The following is a description of a gene set: studied in species Homo sapiens Human Gene Set: chr14q32, and this is the list of marker genes: VRK1, GON7, IGHVII-43-1, CEND1P1, LINC02321, OTUB2, BTBD7 (BTB domain containing 7), IGHVII-65-1, IGHV5-78, IGHD1-14, SNORD114-12, MIR770, IGHVIII-2-1, IGHD4-17, IGHV1-69-2, MIR485 (NCBI Gene Id 574436), SNORD113-8 (NCBI Gene Id 767568), MIR487A, IGHVII-30-1, KIF26A-DT, IGHVII-46-1, DICER1, RAB42P1, SERPINA6 (serpin family A member 6), LINC02279, MIR493, IGHV3-54, MIR412, MIR494, IGHE, SCARNA13 (NCBI Gene Id 677768), SNORD114-23, IGHV3-62, RNU7-30P, MIR377, IGHV1-12, LINC02299, IGHVII-51-2, IGHVII-1-1, IGHV7-40, MIR4710, SNORA11B, IGHJ4, SNORD113-7, IGHD3-9 (immunoglobulin heavy diversity 3-9), RTL1, MIR541, SNORD113-4, IGHV1-58, EFCAB11, IGHV3-29, RNU2-33P, IGHV4-28, IGHV3-52 (NCBI Gene Id 28421), IGHV1-14, IGHV2-26, RN7SL634P, IGHV3-37, MIR203A, LINC02280, IGHD3-22, FAM181A, ATG2B, IGHA2, IFI27L1, SYNE3-AS1, CCDC88C, IGHD5-24, MIR543, LINC02285, KCNK13, TRMT61A-DT, MARK3, ENSG00000285205 (novel transcript), MIR382, RPS6KA5, CDCA4, IGHV3-57, MIR433, FBLN5, LINC00239, IGHVII-49-1, MIR203B, IGHD1-1, MIR411, RN7SL523P, DDX24 (DEAD-box helicase 24), LINC02287, EXOC3L4 (exocyst complex component 3 like 4), PPP4R4, SERPINA3, HSP90AA1, ENSG00000200150, RPL10AP1, IGHV1-3, SNORD114-14, AKT1, IGHV2-70, RN7SKP255, MIR409, MEG8, AMN, RN7SL472P, IGHVII-22-1, MTA1-DT, MIR431, LINC02312, MIR544A, GSC, IGHD3-10, MIR376A2, MIR539, MIR4539, TRAF3 (TNF receptor associated factor 3), MEG3, MIR323B, LINC01550 (NCBI Gene Id 388011), TECPR2, SNORD114-24, LINC02320, LINC00605, PAPOLA-DT, MIR493HG, MIR1197, IGHD2-2, ADIPOR1P2, MIR665, PPP1R13B, TUNAR, IGHV3-35, CINP, ZFYVE21, HOMER2P1, CCDC197, BEGAIN, PPP1R13B-DT, IGHV5-10-1, RIN3, IGHD6-19, LINC00226, BRF1, INF2, MIR4507, BDKRB1 (bradykinin receptor B1), IGHG2, RPL23AP10, COPDA1, MIR8071-2 (microRNA 8071-2), LINC02292, IGHVII-74-1, AK7, IGHM, NDUFB4P11, IGHD6-25, IGHV3-64D, IGHVII-40-1, MIR1193, SNORD114-26, DEGS2, PLD4, IGHJ3, ITPK1-AS1, PEBP1P1, RPL21P12, SNORD114-4, IGHVII-30-21, RPL17P4, IGHVIII-44 (NCBI Gene Id 28345), IGHD2-21, YY1, CLBA1, MIR329-2, TTC7B, ENSG00000230805, DIO3OS, WDR25, MIR654, IGHVII-28-1, DICER1-AS1, ENSG00000258460, IGHVII-60-1, VESTAR, SNORD114-2, IGHV3-33-2, DYNC1H1, IGHV3-65, ATXN3, IGHV4-31, IGHV3-50, RNU4-68P, MIR655, IGHJ3P, IGHV1-46, IGHVIII-76-1, CYB5AP3, ENSG00000201500, CRIP2, C14orf132, SLC25A47, IGHD2-8, MIR4538, RPS20P33, MIR496, IGHV1-69 (NCBI Gene Id 652126), UNC79, SNORD114-29, RPL23AP11, RPL15P2 (ribosomal protein L15 pseudogene 2), MOAP1, LINC02298, IGHV3-79, IGHV3-53, MIR345, BDKRB2 (NCBI Gene Id 624), SNORD114-9 (small nucleolar RNA, C/D box 114-9), IGHVIV-44-1, BAG5, FOXN3, IGHVIII-67-4, ATP6V1G1P1, ITPK1, MIR380 (NCBI Gene Id 494329), TRIP11, IGHVII-62-1, IGHV3-6, IGHVIII-38-1, CKS1BP1 (NCBI Gene Id 317780), SNORD114-19, SLC24A4, RNU6-1258P, RNU6-790P, LINC02914, IGHD6-6, MIR127 (microRNA 127), GSKIP, IGHJ5, LINC02304, PPP2R5C, RPL21P11, LINC02323, TDRD9, IGHD2-15, IGHV7-81, TEDC1, IGHD1-26, PPP4R3A, IGHV3-69-1, SNORD113-2, IGHV3-30-2, IGHV3-38 (NCBI Gene Id 28429), GCSHP2, IGHVIII-47-1, ASB2, RNU6-684P, MIR342, NUDT14, RN7SKP108, RNU6-366P, MIR136, MIR410, SNHG10, IGHV7-4-1, IGHV4-61, IGHV3-23, IGHV7-56, ENSG00000303620, LINC02295, IGHVIII-5-1, TMEM179, CCDC85C, IGHV3-15, MIR1185-1, IGHV1-69D, IGHV2-70D, ENSG00000297609, CPSF2, UBR7, SNORD114-20, CALM1, GOLGA5, SLC20A1P1, SNORD114-10, CLMN (calmin), CCNK, SNORD114-3, FAM181A-AS1, YY1-DT, IGHV3-75, MIR6764, RPS2P4, DIO3, CATSPERB, IGHV3-41, RPL36AP4, MIR758 (NCBI Gene Id 768212), RPSAP5, SERPINA9, SNORD114-1, RNU6-244P, RCOR1, SETD3, SNORD114-6, HMGB3P26, ENSG00000258702, MIR6765, DLK1 (NCBI Gene Id 8788), LINC02325, SNORD113-3, COA8, MIR329-1, SNORD114-28, SNORD114-5, IGHD6-13, IGHV3-73, IGHV3-22, SNORD114-21, IGHD3-3, JAG2, ELK2BP, IGHV1-17, RNU7-160P, ADAM6, IGHG4, WARS1, TNFAIP2, LINC02317, SNORD114-11, MIR487B, IGHV8-51-1 (immunoglobulin heavy variable IGHV8-51-1 (non-functional)), IGHA1, LINC02314, IGHVIII-25-1, LINC00221 (long intergenic non-protein coding RNA 221), IGHV4-39, ENSG00000222095, MIR381, SNORD113-5, IGHV3-43, IGHJ1P, NRDE2, SERPINA2, LINC00677, PRIMA1, IGHV1-68, SERPINA5, IGHV3-60, GPR132, IGHD5-12, RNA5SP389, ENSG00000295850, IGHV1-45, ENSG00000202275, MIR5195, LINC00524, ENSG00000287501, IGHV3-7, MTA1, MIR656, BCL11B, LINC02691, IGHV7-27, LINC02318, ATP5MC1P1 (ATP synthase membrane subunit c locus 1 pseudogene 1), RNU6-91P, IGHV5-51, C14orf180, XRCC3, IGHV3-64, MIR376A1, LINC02291, IGHV3-72, MIR369, RPL21P13, LINC00523, CHGA, MIR495, SIVA1, IGHV4-55, HHIPL1, RN7SL714P, COX8C, IGHV7-34-1, NDUFB1, CHORDC2P, IGHV1-67, IGHJ1 (immunoglobulin heavy joining 1), MIR8071-1, IGHV3-20 (immunoglobulin heavy variable 3-20), IGHV3-30, CYP46A1, FAM30A, SNORD113-6, SERPINA4, IGHD4-11, KLC1-AS1, GPR68, LINC02960, MIR2392, MIR134, RN7SKP92, PAPOLA, IGHVIII-13-1, SNORD113-1, RPL3P4, MIR370, MIR300, POLR3GP1, FOXN3-AS1, ZBTB42, IGHD3-16, IGHVII-67-1, SNORD114-7, IGHD7-27, IGHV6-1, IGHV2-5, IGHVIII-82, IGHV1-2, IGHJ2, MIR432, DGLUCY, IGHV3-32, IGHVIII-67-2, IGHV1-18, MIR379, ADSS1, RPSAP4, IGHG1, ASPG, TCL1B, SYNE3, SLC20A1P2, SNORD114-30, IGHJ2P, IGHVIII-26-1, IGHVII-78-1, EIF5-DT (EIF5 divergent transcript), IGHV4-4, TEX22, IGHV3-63, RN7SKP107, SERPINA11, ENSG00000258716, SNORD114-31 (NCBI Gene Id 767612), IGHV3-33, IGHV3-42, EVL, ATP5MJ, MEG9, AHNAK2, IGHV3-76, LINC02833, TDP1, NPM1P20, IGHVII-15-1, RNU6-1316P, SNORD114-17, SERPINA12, MIR154, RNU1-47P, SNORD114-25, RN7SL546P, CKB, MIR151B, IGHVIII-16-1, BTBD6, IGHVII-44-2, KLC1, TC2N (tandem C2 domains, nuclear, NCBI Gene Id 123036), TCL6, IGHV4-80, IGHV3-71, IGHV3-16, CCDC88C-DT, RPS26P49, ANKRD9, SERPINA13P, IGHV3-25, IFI27, CRIP1, EML1, TMEM121, SERPINA1, SNORD114-13, ENSG00000275154, ENSG00000259097, IGHD5-18 (immunoglobulin heavy diversity 5-18), SNORD114-15, LINC00642, GLRXP2 (glutaredoxin pseudogene 2), GLRX5 (glutaredoxin 5), IGHD5-5, SNORD114-27, MIR337, SNORD114-18, VDAC3P1, ENSG00000222185, TTC7B-AS1, IGHG3, SNORD114-22, MIR323A, LGMN, SNORD112, PSMC1, RAP2CP1, IGHEP1, IGHD4-4, ENSG00000277754, IGHD4-23, FOXN3-AS2, IGHV4-59, IGHV3-21, ENSG00000201710, IGHD, KIF26A, SNORD113-9, SLC25A29, NANOGP7, CDC42BPB, IGHVIII-22-2, IGHVIII-5-2, MIR889 (NCBI Gene Id 100126345), MIR4309, MIR668, MIR4506, SNORA28, IFI27L2, CEP170B, MIR1247, IGHGP, IGHV3-11 (immunoglobulin heavy variable 3-11), MIR299, IGHV3-13, MIR4537, IGHV3-48, IGHV3-47, IGHV4-34, IGHVII-33-1, SERPINA10, LBHD2, ENSG00000258752, MOK, TCL1A, ELK2AP, TRMT61A, IGHV3-19, IGHV3-66, HOMER2P2, WDR20, MIR1185-2, IGHJ6, IGHVIII-67-3, PACS2, RPL13P6, IGHVIII-11-1, IGHV3-74, MIR376B, IGHVII-53-1 (immunoglobulin heavy variable (II)-53-1 (pseudogene)), IGHV3-36, IGHV1-24, ZNF839, RD3L, MIR3173, MIR376C, IGHD1-20, IGHD1-7, SNORD114-16, IGHVII-26-2, EIF5, IGHV3-49, LYSET, ENSG00000298453 (NCBI Gene Id 105370638), ENSG00000307462